The following is a description of a gene set: from publication Chen Y, Wang X (PMID 31504780) studied in species Homo sapiens Human Gene Set: MIR6755_5P Genes predicted to be targets of miRBase v22 microRNA hsa-miR-6755-5p in miRDB v6.0 with MirTarget v4 prediction scores > 80 (high confidence targets)., and this is the list of marker genes: PRSS12, FURIN, GRID1, SPRY3 (sprouty RTK signaling antagonist 3), CD86, ARHGAP18, WBP2, SLC25A2, ANKRA2, NDUFAF3, TNR, BBX, SOX6, TMEM81, SCARB2, CCT6A, DCTD (dCMP deaminase), SLC25A15, QSER1, PPTC7, TUT4, TRIOBP, RFX4, FAM78A, CRNN (cornulin), NDRG2, PRPF4, VWA5A, DTNA, PFDN2, POU3F1, LILRA1, CILP2, PHC3, NPVF